Given this list of marker genes ASAH1, NFS1, NPC2, PFN1, CRLF1, ALDH7A1, UNC13A, LBX1, LFNG, LAMB3, PRKCSH, NUTM2B-AS1, PEX5 (peroxisomal biogenesis factor 5), B3GALT6, EXOSC8, ERBB3, DYSF (NCBI Gene Id 8291), DRC1, ATXN1, INVS, IBA57, DNM2, NSF, GIPC1, MYF6, NDUFB11, MYPN (myopalladin), RMND1, LRP12, MAGEL2, NDUFS7, PEX10, MYL1, TMEM126B, SMPX, RNU4ATAC, TREM2, DSP, AGK, PON2, PIGA, DES, HLA-DPA1, MYBPC1, AIFM1, AMT, DLL3, SLC30A9, MADD, GLI3, SLC6A9, SNRPB, HES7, COLQ, MYH7, CNTNAP1, ACVR1, RPGR, PAX2, MT-TT, ALG1, GLS, ERF, TUFM, FOXJ1, GLUL, DMD, NUP88, LTBP4, COL1A2, NDUFAF8, PLEC, COQ4, CACNA1S, TBCD, LYRM7, RYR1, DNAAF5, SUCLG1, CCNF, HSPG2, VCP, SPEF2, PRIM1, BIN1, SPAG1, ALG14, VRK1, HYDIN, AEBP1, ZC4H2, KIAA0753, PON3 (paraoxonase 3), ESAM, RFT1, ACTA1, POMT1, SLC18A3, OPTN, KIF21A, ZMYND10, USP18 (ubiquitin specific peptidase 18), ABCA12, PEX3, HCCS, NDUFA9, DAG1, COL2A1, POMK, ABCA3, CHAT, CHD7, DNAH9, NDUFS6, GDNF, PIK3CA (phosphatidylinositol-4,5-bisphosphate 3-kinase catalytic subunit alpha), MED11, RNF168, MCM4, MDFIC, SLC25A46, MYH3, MEG3, NBN, LTBP3, BICD2, MECP2, GET3, COQ9, CLXN, VAMP1, PURA, DYM, GFRA1, UNC93B1, DNAI1, CISD2, LIAS, SHPK, AHDC1, COL6A1, CCDC174 (coiled-coil domain containing 174), SYT2 (NCBI Gene Id 6858), LRPPRC, LARS2, ATP8B1 (ATPase phospholipid transporting 8B1), KNSTRN, DDC, GMPPA, VMA21, NDUFB10, HMBS, PRTN3, PEX7, NDUFS8, HLA-B, PLAGL1, NFASC (NCBI Gene Id 23114), DNAAF6, NUP214, AGTR1, COX7B, TMEM43, COL6A3, GLT8D1, DPAGT1, MT-TE (NCBI Gene Id 4556), TEFM, ORAI1, DYNC2I1, PEX11B, NHLRC2, KAT6A, DAO, TARDBP, MRPS14, TSFM, TK2, PEX2, GPC4, GTPBP3, GMNN, TRIM2, UFM1, TRPV4, KCNJ6 (potassium inwardly rectifying channel subfamily J member 6), DDX3X, SLC2A10, CYP27A1, HMGCR, RSPH4A, OSTM1, PEX19, DNAH11, DNAJC21, PON1, EXOSC3, DNAAF2, DCTN1 (dynactin subunit 1), GLYCTK, MT-TN, CLCN6, KIT, RMRP, MTR (5-methyltetrahydrofolate-homocysteine methyltransferase), NDUFB8, ODAD2, STAC3, ERGIC1, DLK1, KARS1, TAMM41, STRA6, RNH1, ABCB4, WFS1, CFAP410, SMCHD1, STAT2, CPS1, DMPK, LRP4, PRDM13, PRPS1, BLM, FOXRED1, TLR3, NRAS, ERBB4, MT-ND1, LIG4, ABCB11, MAMLD1, IFIH1, LAMA2, PRPH, PLAA, RUNX2, SLC52A2, NEK10, PEX14, HSD3B2, COL11A1, PLOD2, LAMB2, ITGA7, COG7, CFAP298, COL1A1, CHRNA1, COL13A1, ACTN2, FREM2, GNPTAB, MEGF10, MCCC2 (NCBI Gene Id 64087), MLYCD, XYLT1, SLC26A4, CPOX, RSPH3, TPM3, NUP188, SCO2, SARS2, SMPD1, DPYD, SLC27A4, PIEZO2, NDUFA10, DNAAF1, PLCB3, EFEMP2, CSF2RA, MESP2, ANXA11, MCCC1, DUX4, NDUFV2, ACOX1, SQSTM1, FIG4, MFN2, TSPYL1, SH3TC2, POLG2, TIMMDC1, GLE1, PTCD3, LARGE1, AGTPBP1, GLA, ODAD4, KCNE3, FGFR3 (fibroblast growth factor receptor 3), CFAP300, LAMA3, EDN3, LTBP1, OFD1, SCYL2, TRIP4, TBCK, LMNA, TFG, MATR3, MAP3K20, VARS2, SMPD4, NALCN, NEK1, SCN4A, TBK1, MT-TL1, ODAD1, RIPPLY2, FLNA, FARSB, LRRC56, SYNE1, CHMP2B, HTRA2 (NCBI Gene Id 27429), MORC2, WDR19, DNAJB4, DTYMK, SMAD4, SOD1, OCRL, NUBPL, DNAH5, CSGALNACT1, ADGRG6, MPZ, SMN1, NPHS1, FOXI1, DNAL1, SEMA3E, BMPER, PEX13, DNAAF11, AHCY, MUSK, CCDC39, SF3B4 (splicing factor 3b subunit 4), TCOF1, GPX4, DNAAF3, LMOD3, MTFMT, AK9, NDUFAF3, SFTPB, SRP54, CSF2RB, TRMU, RSPH9, MT-ND2, FAT4, NSUN2, PLPBP, CHD6, INPP5K (NCBI Gene Id 51763), DYNC2I2 (dynein 2 intermediate chain 2), TOR1A, GARS1, NDUFA6, CCDC65, PDCD1, NDUFAF1 (NCBI Gene Id 51103), TMEM70, CNTN1, CANT1, PIK3CD, LAMC2, NEB, CSPP1, MYL2, EGR2, NME5, TPM2, GCSH, COA8, MYD88, CCNO, NME8, PHYH, DNAAF4, IFNG, AGT, JAK2, MTMR14, PLEKHG5, LRP5, CHRNB1, NDUFS4 (NCBI Gene Id 4724), MYOD1, ECHS1, CAPNS1, NDUFAF5, SON, DNM1L, PEX1, CTLA4, ASNS, IGHMBP2, MYO9A, HCK, BDNF, HIBCH, ATAD1, MCIDAS, PEX12, SFTPC, MYOT, RTL1, CHCHD10, MT-TL2, DST (dystonin), COX6A2, IFT172, SPTLC1, GMPPB, DYNC2H1, CFAP221, OAS1, CHRNE (NCBI Gene Id 83405), CHRNG, NDUFA1, ASCC1, PIP5K1C, TWNK (NCBI Gene Id 60508), CCBE1, NDUFAF4, HPDL, IFT81, MPV17, SLC25A26, CLPB, DOCK11, LBR, TICAM1, LONP1, FKRP (NCBI Gene Id 79147), IFT140, TXNDC15 (NCBI Gene Id 79770), ADPRS, CFL2, POMT2, SNAP25, COL6A2, HRAS, COX14, SPEG, STIM1, RSPH1, PEX6, SLC25A24, SLC52A3, FKBP10, RALGAPA1, SLC34A2, FBN1, WT1, PAX7, ACE, NR1H4, CEP120, MYO1H, GAS2L2, GSC, UBA1, MGME1, STK36, COL11A2, SOX9, REN, RNASEH1, TTC12, SLC25A1, KCNJ10, FGFR2, TSEN54, NDUFA11, HADHA, LIPT2, NEFH, PTPN22, HADHB, CTSD, FLNB, DNMT3B, FUS, COL3A1, ORC4, SLC26A2, UBQLN2, TNPO3, CRYAB, HLA-DPB1, LIFR, NOTCH2NLC, FRG1, SNUPN, NDUFS3, SPG11, HACD1, NDUFS1, DOK7, INPPL1, CHRND, DNAI2, SLC25A20, ASXL1, PEX26, WDR35, SEPTIN9, PLP1, DNAJB13, GALC, KLHL40, FLNC, DPM2, PSAP, FHL1, BAG3, FOXF1 (forkhead box F1), NFU1, TSC2, PEX16, GATA2, CFAP74, GRM7, POLR1C, TTN, DUX4L1, YARS2, CDC45, PBX1, NKX2-1, MED12, SLC7A7, MYH11, EMD, GALK1, SLC5A7, ODAD3, TNNT1, SLC6A5, TRAPPC11, GPC3, CLCF1, RAPSN (receptor associated protein of the synapse), PMP22, RILPL1, PLOD1, TRAF3, PHOX2B, CDT1, CUL7, FBLN5, GNB2, FLAD1, CCDC40, PRUNE1, HNRNPA2B1, MICOS13, FKTN, NDUFAF2, SUCLA2, SPOP, TUBA1A, HYMAI, DZIP1L, CDC6, COL25A1, NDUFB3, RNASEH2A, VAPB, ORC6, AGGF1, ORC1, GGPS1, ENPP1, ALDH1A2, ADAMTS3, CPT2, SBF2, IFT80, MTM1, SEC63, NAXE, SLC25A4, ATXN2, SBDS, EXOSC9, UBE3B, ARSL, NDUFS2, ACADVL, MYMK, TAF15, PKHD1, DYNC2LI1, BSCL2, SURF1, KBTBD13, G6PC3, BOLA3, MT-ND3, FCSK, PLCB4, MAP2K1, PDHA1, AAAS, SLC19A3, NDUFB9, POGLUT1, FGFR1, TRAF7, RRM2B, MB, TPI1, ITGA3, ZNF148, FAM20C, TMEM231, BCHE, SELENON, POLR1B, AFF3, ALAD, TRMT10C, TSC1, GAA, GFPT1, KLHL41 (NCBI Gene Id 10324), SLC25A3, PPARGC1A, BRAF, POLR1D, KIF22 (NCBI Gene Id 728037), JUP, DNAH1, GOSR2, ANG, HNRNPA1, AGRN, TTC21B, MTTP, SYNE2, POLG, COL12A1, IRF4, MARS1, NDUFV1, LAMP2 (lysosomal associated membrane protein 2), here is a description of the gene set: species: Homo sapiens Human Gene Set: HP_RESPIRATORY_INSUFFICIENCY Respiratory insufficiency